The following is a description of a gene set: species: Homo sapiens part of: RNA Polymerase III Transcription Abortive initiation, the repetitive formation of short oligonucleotides, is a ubiquitous feature of transcriptional initiation. This Pathway contains events inferred from events in Saccharomyces cerevisiae. Reactome Pathway: RNA Polymerase III Abortive And Retractive Initiation, and this is the list of marker genes: SNAPC1, POLR3H, GTF3C4, GTF3C6, GTF3C1 (NCBI Gene Id 2975), POLR2F, POLR3E (RNA polymerase III subunit E), POLR3B, NFIX, POLR3A, BRF1, GTF3C3, POLR1D, TBP, POU2F1, POLR2K, POLR2H, GTF3A, BDP1, POLR2E, POLR3G, SNAPC2, POLR3K, GTF3C2, POLR3F, SSB, SNAPC5, SNAPC3, ZNF143, CRCP, POLR3D, GTF3C5, SNAPC4 (small nuclear RNA activating complex polypeptide 4), POLR3C, POLR1C (NCBI Gene Id 9533), POLR2L, NFIA, NFIB, BRF2, POLR3GL, NFIC